Given this list of marker genes Oprk1, Wipf2, Zfp300, Ptpn12 (protein tyrosine phosphatase, non-receptor type 12), Hyal5, Rab1a, Kcnj10, Lrrc39, Scml2, Rps20, Gsg1l, Car9, Patl1, Mrpl15, Pdlim5, Mctp1, Gpr82, Itga1, Naa30, Rassf2, Sp1, Kif3c, Crbn, Pabpc4l, Phf3, Cd53, Pold4, Svs5, Raver2, Tmtc1, Shoc2, Gkn2, Pcbp2, Niban3, Svs3b, Krtap1-3, Nek5, Kcnmb2, Ranbp9, Clec4g, Nphp3, Iqcf3, Rsrc1, Cdk12, Sbk3, Arid3c (AT-rich interaction domain 3C), Rph3al, Numa1, Sh3gl2, Nme7, C1qtnf1, Cd84, Cacng5, Rprd1a, Mlf2, Ccdc169, Hdac2, Kat6a (NCBI Gene Id 60407), here is a description of the gene set: Genes predicted to be targets of miRBase v22 microRNA mmu_miR_1969 in miRDB v6.0 with MirTarget v4 prediction scores > 80 (high confidence targets). species: Mus musculus from publication Chen Y, Wang X (PMID 31504780) Mouse Gene Set: MIR_1969